The following is a description of a gene set: Any process that activates or increases the frequency, rate or extent of neutrophil degranulation. Mouse Gene Set: GOBP_POSITIVE_REGULATION_OF_NEUTROPHIL_DEGRANULATION species: Mus musculus, and this is the list of marker genes: Cd177, Ptafr, Itgb2, Lypd10, Lypd11, Itgam, Itgb2l